Given this list of marker genes TTC29, BLNK, FFAR1, GID8, CD79B, DNAJC3, ZBTB24, TALDO1, CCDC28A, EZH1, CCNG2, SYNPR, PRPH2, POLR1D, KLHL7, INPP5A, NR1D2, VRTN, PTCH2, KCNA1, DIPK1A, ARMT1, BCAR3, MGST1 (NCBI Gene Id 4257), PRDM14, FKBP6, STX18, MAGEF1 (NCBI Gene Id 64110), CDK3 (cyclin dependent kinase 3), MIR551B, NECAP1 (NCBI Gene Id 25977), ZNRF1, BMF, SLC25A37, IGF2, NGLY1, MIR130B, ARHGAP6, TACR1, FKBP1B, EIF4A2 (eukaryotic translation initiation factor 4A2), TMEM150A, WDR45, IQCE, CCM2L, PDZPH1P, IRS4, ISM2, MNS1, LRCH1, ST6GALNAC5, CYB561, TBCEL, ELN, FBXO8, PTPN12, NAALADL2 (N-acetylated alpha-linked acidic dipeptidase like 2, NCBI Gene Id 254827), IGF1, ST3GAL1, TMEM210, S100A16, C1QTNF3 (C1q and TNF related 3), MYO15A, DDAH1, HSD3B2, SLC38A3, SOX10, SCOC, PDZRN4, AGO2, DCTN4, SLIT2, SCD5, NSMCE3, ACTR8, PRIMA1, RAP2B, FAM32A, CBLL1, MAP3K21, WNT5A, VPS26C, WASF3, MGAT1, PKDREJ (NCBI Gene Id 10343), SNX7, DDX24, FAM118A, GMFG, CSF3R, HRH1, KRT75, CEACAM19, TMEM167B, GMEB2, ALG14, CCDC166 (coiled-coil domain containing 166), TMEM234, SUGP1, SLC28A3, ZDHHC15, POU2F1, FCAMR, KCTD6, KDM5B, KCNMB4 (NCBI Gene Id 27345), CD40LG, OGFOD1, DSG4, NRF1, AXIN2, IDH3B, MYCT1, CCDC110, NKX2-6 (NCBI Gene Id 137814), GLYCAM1, ADAMTS14, STX8, TTLL7, PDGFRB, CDC42EP3, CTCFL, BPIFA1, EEIG2, ARL14, SPATA32, NEBL, PGAP1, CATSPERD, DARS2, SOAT1, CNST, KCNK9, PATL1, CCL22, ATG12 (NCBI Gene Id 9140), ITGAX, COL14A1, C16orf89, C1orf216, ETS2, DLEU7, KRT72, H2BC21, MMP17, CNR1, HOXD3, here is a description of the gene set: Human Gene Set: GSE13522_CTRL_VS_T_CRUZI_BRAZIL_STRAIN_INF_SKIN_UP from publication Chessler AD, Unnikrishnan M, Bei AK, Daily JP, Burleigh BA (PMID 19201883) studied in species Homo sapiens To investigate the early host response triggered by three different strains of Trypanosoma cruzi at a local infection site, changes in host gene expression were monitored in a murine intradermal infection model using Affymetrix oligonucleotide arrays. Robust induction of IFN-stimulated genes (ISGs) was observed in excised skin 24 hours post-infection where the level of ISG induction was parasite strain-dependent with the least virulent strain triggering a muted IFN response. Infection of mice immunodepleted of IFNγ-producing cells or infection of IFNγ-deficient mice had minimal impact on the IFN response generated in T. cruzi infected mice. In contrast, infection of mice lacking the type I IFN receptor demonstrated that type I IFNs are largely responsible for the IFN response generated at the site of infection. These data highlight type I IFNs as important components of the innate immune response to T. cruzi the site of inoculation and their role in shaping the early transcriptional response to this pathogen. We used microarrays to detail the local host transcriptional response to intradermal T. cruzi infection in WT mice and mice depleted of NK cells, or deficient in IFN-gamma or type I IFN responses. Additionally we compared the local host-transcriptional response generated to infection with 3 different strains of Trypanosoma cruzi (Y, Brazil, and G). Genes up-regulated in skin from BALB/c mice after injection of: control versus Trypanosoma cruzi (strain Brazil).